The following is a description of a gene set: Human Gene Set: REACTOME_INCRETIN_SYNTHESIS_SECRETION_AND_INACTIVATION species: Homo sapiens Incretin synthesis, secretion, and inactivation, and this is the list of marker genes: TCF7L2, GRP, GIP, DPP4, GNB1, SPCS2, GNAT3, ISL1, GNG13, GATA4, SPCS1, CDX2, PCSK1, SEC11A, LEP, SPCS3, FFAR4, GPR119, CTNNB1, FFAR1, SEC11C, GNB3, GCG, PAX6